Given this list of marker genes Rimbp2, Insc, Sapcd2, Hamp2, Erc2 (ELKS/RAB6-interacting/CAST family member 2), Phldb2, Dctn1, Erc1, Numa1, Nr3c2, Ctnna2, Rims1, Pclo, Fabp2, Pkd2 (NCBI Gene Id 77380), Mark2, Gucy1b1, Clasp1, Sptbn5, Rims2, Phldb1, Fabp1, Ctnnb1, Stxbp1, Hamp, Gck, Tchp (NCBI Gene Id 77832), Myo5b, Prkcz, Gpsm2, Clasp2, Ctbp2, Iqsec2, Unc13a, Ctnnd1, Osbpl2, Bsn, Ppfia3, Nlrp5, Ctbp1, Rims3, here is a description of the gene set: studied in species Mus musculus The complete extent of cell cortex that underlies some some region of the plasma membrane. Mouse Gene Set: GOCC_CELL_CORTEX_REGION